Given this list of marker genes Gins1, Pole3, Pold3, Mcm4, Mcm3, Ino80c, Ino80, Ino80b, Mcrs1, Pola1, Dna2, Lig3, Tert, Nfrkb, Rad50, Mre11a, Pold2, Tfpt (NCBI Gene Id 69714), Ino80d, Actl6a, Ruvbl2, Pot1b, Uchl5, Pcna, Nbn, Lig1, Pot1a, Pole, Dclre1b, Actr5, Yy1, Ruvbl1, Actr8, Ino80e, Nucks1, Mcm7, here is a description of the gene set: The DNA metabolic process in which an existing DNA strand is extended by activities including the addition of nucleotides to the 3' end of the strand. species: Mus musculus Mouse Gene Set: GOBP_DNA_STRAND_ELONGATION